Given this list of marker genes GOT1L1, ATP5MC1, ALDH7A1, RNF26, EMC7, DAD1, ATP5PO, NDUFA5, UBIAD1, SLC48A1, COPA (COPI coat complex subunit alpha), EIF2S2, HDLBP, EVC, C11orf58, ABHD13, SPCS2, GPATCH2, PSME4, ITFG1, SCFD1, CCDC134, GINS2, TMTC4, NBEA, PIGK, TMEM184B, MAGED2, SLAMF7, NUP43, NOP9, TIMM21, STARD5, DESI1, TMEM41B, HSPA13, TBL2, ATF6, RPA2, INPP1, KCNN4, TIMM23, ALDH9A1, GCAT, EXO1, PRLR, UFM1, EIF4E3, ARSB, MLEC (NCBI Gene Id 9761), TMEM214, RPP30, DTWD1, PKD2L2, OSTC, SLC30A4, DHRS1, CXCR4, CAPN5, FTL, NCEH1, IQCB1, OXCT1, ERN1, GOLGA3, MYDGF, ZFYVE21, NDC80, SRP9 (NCBI Gene Id 6726), SAR1B, MASTL, UXS1, GAS2L1, SEC23B (SEC23 homolog B, COPII coat complex component), ATP2A2, CKS2, OSTM1, LGALS3BP, SIVA1, PREB, SLC16A6, CLCN5, HS2ST1, MNS1 (NCBI Gene Id 55329), GPR65, PLCXD2 (NCBI Gene Id 257068), SMDT1, ADA, MAD2L1, CENPA, CNIH1, GALNS, CLPTM1, NPLOC4, SRPRA, RNASEH2B, BDH1, YARS1, CERS6, UPB1, PRAF2, NDUFS6, AGPAT5, PPP6C, MED23, TACC2, PSMC3IP, SRP68, PNPO, NUDT4, EIF1AX, PSMC1, IL18, CEP76, MRPS14, TUBE1, TMEM147 (transmembrane protein 147), MCM3, SLC35B1, FTSJ1, UBE2A, IFT46, HSD11B1, NUDT5, MARS1, DMAC1, CIP2A, GPR89B, APOO, PGK1, LINC01160, UBAC2, DPAGT1, ZMPSTE24, ST7, SEC61A1, NODAL, CPTP, GLA, EIF2B1, ELL2, VAMP3, UTP6, AP1S1, CSDC2, STAC2 (SH3 and cysteine rich domain 2), IARS1, SPCS3, EFNB3, SPCS1, KIAA1217, CKS1B, SMPD1, DIAPH3, NDUFB9, GOT2, DNAJA3, CDV3, MSRB1 (NCBI Gene Id 51734), MANF, DCLRE1A, IGSF8, ALPL, YIPF3, HROB, KARS1, TMCO1, CD44, MVB12A, NDUFB2, BST2, SLC43A3, PIGF (NCBI Gene Id 5281), COQ7, NDUFA9, UBE2H, ZNF280B, ASF1B, LGALS1, KRTCAP2, PRKCSH, ATP5ME, TXNDC15 (thioredoxin domain containing 15), RARS1, SLC39A11, CYP4F22, MYB, CYB561D2, AVEN, ITGB1BP1, DUSP22, TASP1, ORMDL2, IMPA2, HSP90B1, TEDC1, GOLPH3L, TMX1 (thioredoxin related transmembrane protein 1), VMP1, SLC1A4, here is a description of the gene set: Human Gene Set: GSE40273_GATA1_KO_VS_WT_TREG_UP from publication Fu W, Ergun A, Lu T, Hill JA, Haxhinasto S, Fassett MS, Gazit R, Adoro S, Glimcher L, Chan S, Kastner P, Rossi D, Collins JJ, Mathis D, Benoist C (PMID 22961053) Genes up-regulated in T reg: GATA1 knockout versus wildtype. species: Homo sapiens The transcription factor FoxP3 partakes dominantly in the specification and function of FoxP3+ CD4+ T regulatory cells (Tregs), but is neither strictly necessary nor sufficient to determine the characteristic Treg transcriptional signature. Computational network inference and experimental testing assessed the contribution of several other transcription factors (TFs). Enforced expression of Helios or Xbp1 elicited specific signatures, but Eos, Irf4, Satb1, Lef1 and Gata1 elicited exactly the same outcome, synergizing with FoxP3 to activate most of the Treg signature, including key TFs, and enhancing FoxP3 occupancy at its genomic targets. Conversely, the Treg signature was robust to inactivation of any single cofactor. A redundant genetic switch thus locks-in the Treg phenotype, a model which accounts for several aspects of Treg physiology, differentiation and stability.